The following is a description of a gene set: species: Mus musculus Binding to a 14-3-3 protein. A 14-3-3 protein is any of a large family of approximately 30kDa acidic proteins which exist primarily as homo- and heterodimers within all eukaryotic cells, and have been implicated in the modulation of distinct biological processes by binding to specific phosphorylated sites on diverse target proteins, thereby forcing conformational changes or influencing interactions between their targets and other molecules. Each 14-3-3 protein sequence can be roughly divided into three sections: a divergent amino terminus, the conserved core region and a divergent carboxy-terminus. The conserved middle core region of the 14-3-3s encodes an amphipathic groove that forms the main functional domain, a cradle for interacting with client proteins. Mouse Gene Set: GOMF_14_3_3_PROTEIN_BINDING, and this is the list of marker genes: Ddit4 (NCBI Gene Id 74747), H2-M10.1, H2-M10.2, Cftr, Dab2ip, Prkcz, Trp53, Foxk1, H2-Q7, Zfp36, Kif13b, H2-M5, Nfatc2, Ripor2, H2-K1, H2-M2, Prkce, Rbm7, Hdac7, Zfp36l1, H2-Q2, Tbc1d22a (NCBI Gene Id 52703), Esr1, Srpk2, Pi4kb, Tsc2, Synpo2, H2-Q10, Aanat, H2-Q6, H2-D1 (histocompatibility 2, D region locus 1), Irs2, Tbc1d22b, Tmcc3, Ripor1, Klhl22, H2-M10.6, Sik1, Akt1, Ywhaq, Bad, Ppp1r12a, H2-T22, Rptor, Arrb2, Ksr1, Nek1 (NCBI Gene Id 52422), H2-M10.4, H2-M11 (NCBI Gene Id 224754), H2-Q1, Kcnh1